The following is a description of a gene set: studied in species Homo sapiens Genes down-regulated in hepatocellular carcinoma of ACOX1 knockout mice. Human Gene Set: LEE_LIVER_CANCER_ACOX1_DN Genetically modified mice have been extensively used for analyzing the molecular events that occur during tumor development. In many, if not all, cases, however, it is uncertain to what extent the mouse models reproduce features observed in the corresponding human conditions. This is due largely to lack of precise methods for direct and comprehensive comparison at the molecular level of the mouse and human tumors. Here we use global gene expression patterns of 68 hepatocellular carcinomas (HCCs) from seven different mouse models and 91 human HCCs from predefined subclasses to obtain direct comparison of the molecular features of mouse and human HCCs. Gene expression patterns in HCCs from Myc, E2f1 and Myc E2f1 transgenic mice were most similar to those of the better survival group of human HCCs, whereas the expression patterns in HCCs from Myc Tgfa transgenic mice and in diethylnitrosamine-induced mouse HCCs were most similar to those of the poorer survival group of human HCCs. Gene expression patterns in HCCs from Acox1(-/-) mice and in ciprofibrate-induced HCCs were least similar to those observed in human HCCs. We conclude that our approach can effectively identify appropriate mouse models to study human cancers. from publication Lee JS, Chu IS, Mikaelyan A, Calvisi DF, Heo J, Reddy JK, Thorgeirsson SS (PMID 15565109), and this is the list of marker genes: LMCD1, C4BPA, KHK, G6PC1, CYP2F1, HPD, MASP1, HSD11B1, SERPINA1, NR1H3, SLC37A4, ORM1, RNASE4, TPM2, RGN, REPS1, TDO2, CPOX, LECT2, GPR37, SLCO2B1, CA3, AASS, TNFRSF10B, LIPC, DPP4, SFTPD (surfactant protein D), ETNK2, MCM3AP, EGFR, TNNT3, APOC4, GSTA3, PRODH, CYP4F2, CYP26A1, ITIH1, TNNC2, OTC, PAH, PHLDA1, PPP1R3C (protein phosphatase 1 regulatory subunit 3C), NINJ1, HGD, SELENBP1, AKR1C1, MBL2, OAT, ELANE, IL1RAP, HBP1, VPS11, MCM10, AKAP11, CYP7B1, SLC27A5, MYH1, GOT1, BAAT, HAL, SLC29A1, PIPOX, ORM2, ATP2A1, CKMT2